The following is a description of a gene set: Reactome Pathway: Cytosolic sensors of pathogen-associated DNA part of: Innate Immune System This event has been computationally inferred from an event that has been demonstrated in another species.<p>The inference is based on the homology mapping from PANTHER. Briefly, reactions for which all involved PhysicalEntities (in input, output and catalyst) have a mapped orthologue/paralogue (for complexes at least 75% of components must have a mapping) are inferred to the other species. species: Mus musculus electronically inferred by orthology from the curated human pathway, and this is the list of marker genes: Irf3, Nfkb2, Myd88, Rela, Ep300, Trim32, Sting1, Dtx4, Ctnnb1, Rps27a, Nkiras1, Ubb, Nlrp4c, Ikbkb, Aim2, Nfkbib, Irf7, Nfkbia, Trim56, Mre11a, Ddx41, Nfkb1